Given this list of marker genes CLCN4, DOLPP1, SOX12, LRRC47, ATXN7L3, MICALL1, SLC6A9, SCAF1, DDX54, ELF4 (E74 like ETS transcription factor 4), DISC1, MUL1, ELFN2, ABCC5, KASH5, SYP, TCL1B, RFFL, NACC1, PLEKHO1, UBE2O (NCBI Gene Id 63893), AMBRA1, TEF, BCORL1, ASB6, ARPC5, PHOSPHO1, STK24, FOXP4 (NCBI Gene Id 116113, forkhead box P4), CPEB1, SUFU (SUFU negative regulator of hedgehog signaling), SAMD4B, CELF5, ZNF500, KCNIP3, PLCB1, STK40, NEXMIF, LASP1, ARHGEF4, TSPAN11, SHANK1, ACAP3, KLK4, COL1A1, ARK2C, HDDC3, DNALI1, DMWD, NNAT, LNPK, ERI3, SLC52A3, CBX6, OBSL1, DAP, CALM3, EVC, RPUSD1, RNPEPL1, SDR16C5, C1QTNF6, ATG4D, ADAR, LHX6, TMEM41A, TMEM150A, RIMS4, CSMD2, RAC2, ROR2, ENC1, COPS7B, SLC11A2, NFIC, RGMA, MKRN2, OTUD5, SEPTIN9, ZNF608, TRABD2B, LZTS3, PGRMC2, WNT9B, MAPKBP1, G3BP2, DUSP8, BEND3, ST6GALNAC6, BAP1, HIC2, CLDN23, GRM4, ATP10B, SCN4A, MFSD12, CRIP3, CADM3, CELSR2, APBB1, PYGB, FBXL16, KDM5B, RAD9B, NAT8L, NFATC2, NECTIN1, CDC42SE1, S100A16, FRMD3, TEC, PNKD, TMEM184B, NRSN2, CIMAP1C, SNX19, GLP1R, MED28, TMEM68, NAV1, ASB14, PLA2G6, SLC20A2, PDAP1, MAP1LC3A, ADGRL1 (NCBI Gene Id 79732), DLGAP3, PACS1, PAQR8, NCS1, ENSG00000187186, ODC1, FAM222B, ARB2A, here is a description of the gene set: Human Gene Set: MIR3184_5P Genes predicted to be targets of miRBase v22 microRNA hsa-miR-3184-5p in miRDB v6.0 with MirTarget v4 prediction scores > 80 (high confidence targets). from publication Chen Y, Wang X (PMID 31504780) species: Homo sapiens